Given this list of marker genes ANK3, VAMP2, KCNE2, KCNE1, SUMO1, KCNE3, KCNAB1, KCNRG, KCNQ1, here is a description of the gene set: Any process that modulates the frequency, rate or extent of delayed rectifier potassium channel activity. species: Homo sapiens Human Gene Set: GOBP_REGULATION_OF_DELAYED_RECTIFIER_POTASSIUM_CHANNEL_ACTIVITY